The following is a description of a gene set: Peripheral tolerance induction is critical for the maintenance of self-tolerance and can be mediated by immunoregulatory T cells or by direct induction of T cell anergy or deletion. While the molecular processes underlying anergy have been extensively studied, little is known about the molecular basis for peripheral T cell deletion. Here, we determined the gene expression signature of peripheral CD8+ T cells undergoing deletional tolerance, relative to those undergoing immunogenic priming or lymphopenia-induced proliferation. From these data, we report the first detailed molecular signature of cells undergoing deletion. Consistent with defective cytolysis, these cells exhibited deficiencies in granzyme up-regulation. Furthermore, they showed antigen-driven Bcl-2 down-regulation and early up-regulation of the pro-apoptotic protein Bim, consistent with the requirement of this BH3-only protein for peripheral T cell deletion. Bim up-regulation was paralleled by defective IL-7Ra chain re-expression, suggesting that Bim-dependent death may be triggered by loss of IL-7/IL-7R signaling. Finally, we observed parallels in molecular signatures between deletion and anergy suggesting that these tolerance pathways may not be as molecularly distinct as previously surmised. species: Homo sapiens Human Gene Set: GSE14699_NAIVE_VS_DELETIONAL_TOLERANCE_CD8_TCELL_UP Genes up-regulated in CD8 T cells: naïve versus undergoing deletional tolerance. from publication Parish IA, Rao S, Smyth GK, Juelich T, Denyer GS, Davey GM, Strasser A, Heath WR (PMID 19204323), and this is the list of marker genes: RFLNB, EML5, TRIM34, MBD5, KIF1B, WDR13, NSG2, MYC, CCND2, KAT6B, CCNA1, SYT8, CRIPTO, ELOVL7, SCML4, CD55, PPP1R13B, LRRC23, SLC6A19, CCR9, SLC49A4, LRP6, CD226, TCP11L2, SSBP2, CEP68, HDAC4, MIR598, TSC22D3, RASGRP1, NLRC5, FOXO1, L3MBTL3, TDRKH, PATJ, TANC1, ANGPTL1, TNRC6C, FOXJ2, HSPBAP1, PLEKHA1, CNGA1, TREML2, CNTNAP3, FNTB, ARHGAP35, KIZ, TCF7, SESN1, IL27RA, LDHB, RAPGEF4, FBXL20, USP28, KLF3, TET1, SMAD7, ITGAE, USP24, DAPL1, FAM168A, CHST15, ARHGAP15, RPL19 (NCBI Gene Id 6143), FBXO32, EPHX1, ST6GAL1, MGRN1, FAM193B, SNX29, ADCY7, SLC43A2, PUS3, AMPD1, KBTBD11, LDLRAP1, CARD6, TGFBR3, PRG4 (proteoglycan 4), TECPR1, MIR302D, LEF1, DZIP1, ZNF318, SPACA1, NOP53, ACP5, SELE, MAPK8IP3, TULP4, SIDT1, ZHX2, SLC39A2, ADGRL2, IL7R, PNPLA7, GRIA3, METTL8, NEDD4L, ZXDC, IL6ST, PDK1, HDAC7, OVGP1, SPRED2, SH3BP5, IQSEC1, INPP4B, MICU3, BICRA (BRD4 interacting chromatin remodeling complex associated protein), SLC17A9, IL21R, ADAMTS6, SMAD1, YPEL1, RAB3IP, SLC12A7, APPL2, XKRX, TCF20, EFNA4, FOXP1, TIMP2, TNFSF8, ITPR2, PPM1H, ZFP82, GRK1, NSD3, DPP4, PHF21A, APC, BACE1, THUMPD2, MYLIP, KDM5B, MFHAS1 (NCBI Gene Id 9258), TTC3, ABTB3, SYNE1, ASH1L, TMEM106B, RNF167, CRIM1, TRIP6, IKBKE, MPPE1, TRAT1, TOX, BCOR, AFP, CCR7 (NCBI Gene Id 1236)